Given this list of marker genes CTBP1 (NCBI Gene Id 1487), TP63, FGFRL1, PIGG, PPP2R1A, MINPP1, RBM8A, TXNDC15, NSD2, MYRF, DHX37, CPLX1, CYP17A1, TOE1, WNT7A, NELFA, WNT4, LETM1, FANCL (NCBI Gene Id 55120), ARID1B, GATA3, CYP11A1, AR, here is a description of the gene set: studied in species Homo sapiens Aplasia of the uterus A congenital defect characterized by absence of the uterus. Aplasia refers to the failure of an organ to develop during embryonic growth and development due to the absence of primordial tissue. Human Gene Set: HP_APLASIA_OF_THE_UTERUS